The following is a description of a gene set: The process in which the anatomical structures of the neurocranium are generated and organized during the embryonic phase. The neurocranium is the portion of the vertebrate skull surrounding the brain. studied in species Mus musculus Mouse Gene Set: GOBP_EMBRYONIC_NEUROCRANIUM_MORPHOGENESIS, and this is the list of marker genes: Med12, Ndst1, Tgfb3 (NCBI Gene Id 21809), Gli3, Mthfd1l, Tulp3, Fgf8, Tgfb2, Hoxa1, Fuz